Given this list of marker genes ZPBP, CCDC62, GGN, DPY19L2 (NCBI Gene Id 283417), CCIN, C2CD6, CT55, SPACA1, SPATA16, here is a description of the gene set: Any structural anomaly of the acrosome resulting in a round sperm head. Globozoospermia species: Homo sapiens Human Gene Set: HP_GLOBOZOOSPERMIA